Given this list of marker genes FLAD1, RFK, SLC52A3, ACP5, SLC52A2, ENPP1, SLC52A1, here is a description of the gene set: Vitamin B2 (riboflavin) metabolism studied in species Homo sapiens Human Gene Set: REACTOME_VITAMIN_B2_RIBOFLAVIN_METABOLISM